The following is a description of a gene set: Mouse Gene Set: GOBP_NEGATIVE_REGULATION_OF_OSTEOCLAST_DEVELOPMENT species: Mus musculus Any process that stops, prevents or reduces the frequency, rate or extent of osteoclast development., and this is the list of marker genes: Tjp2, Ltf, Fbxw7, Fbn1, Cldn18